Given this list of marker genes Fyn, Agap2, Gria2, Bcl2l2, Grin3b, here is a description of the gene set: Mouse Gene Set: GOBP_CELLULAR_RESPONSE_TO_GLYCINE Any process that results in a change in state or activity of a cell (in terms of movement, secretion, enzyme production, gene expression, etc.) as a result of a glycine stimulus. species: Mus musculus